Given this list of marker genes Oma1, Mief1, Prkn, Vat1, Tfrc, Mul1, Zdhhc6, Adck1, Mfn1, Huwe1, Mtch2, Dnm1l, Bnip3, Opa1, Yme1l1, Pld6 (NCBI Gene Id 194908), here is a description of the gene set: Any process that modulates the frequency, rate or extent of merging of two or more mitochondria within a cell to form a single compartment. Mouse Gene Set: GOBP_REGULATION_OF_MITOCHONDRIAL_FUSION species: Mus musculus